The following is a description of a gene set: Human Gene Set: KEGG_MEDICUS_PATHOGEN_HCMV_GB_TO_PDGFR_RAS_ERK_SIGNALING_PATHWAY Pathway Definition from KEGG: UL55 -> PDGFR -> GRB2 -> SOS -> RAS -> RAF -> MEK -> ERK HCMV gB to PDGFR-RAS-ERK signaling pathway. Pathway ID: N00386. Pathway type: Pathogen. Pathway class: nt06167 Human cytomegalovirus (HCMV). studied in species Homo sapiens, and this is the list of marker genes: MAP2K2, ARAF (A-Raf proto-oncogene, serine/threonine kinase), GRB2, MAPK1, MAPK3, RAF1, NRAS, BRAF, SOS1, MAP2K1, PDGFRA, KRAS, HRAS, PDGFRB, SOS2